The following is a description of a gene set: from publication Chaussabel D, Semnani RT, McDowell MA, Sacks D, Sher A, Nutman TB (PMID 12663451) species: Homo sapiens Monocyte-derived dendritic cells (DC) and macrophages (MΦ) generated in vitro from the same individual blood donors were exposed to five different pathogens, and gene expression profiles were assessed by microarray analysis. Responses to Mycobacterium tuberculosis and to phylogenetically distinct protozoan (Leishmania major, L. donovani, Toxoplasma gondii) and helminth (Brugia malayi) parasites were examined, each of which produces chronic infections in humans yet vary considerably in the nature of the immune responses they trigger. Genes up-regulated in comparison of macrophages exposed to L. donovani versus macrophages exposed to M. tuberculosis. Human Gene Set: GSE360_L_DONOVANI_VS_M_TUBERCULOSIS_MAC_UP, and this is the list of marker genes: GATC, HSPA1A, TRIP13, LRIT1, SORBS3, USP24, TIAM1, TUBB7P, NPC1, ACP5, CYB561D2, PECAM1, CLN3, AARS1, GRIK2, MGA, BRD2, TMEM184B, ZNF148, MOAP1, PPP2R5A, SVIL, TDRD3, EXPH5, CHST15, HYOU1, TAX1BP1, STK10, CENPS, CHERP, GFUS, COL4A5, DAB2, TFRC, MAPKAPK5, HAL, TBX19, CCR7, CUL5, TLN2 (talin 2), LY86, CALML3, GPC3, C6orf120, ALDH1B1, JADE2, RPL10, LIPA, PRIM1, RAMP1, LPAR2, DNAH7, BNIP3L, ZNF263, SERINC5, IL1R1, MERTK, SIAH1, IRF4, KDM4C, NAP1L1, C1orf216, HOMER3, PRCP, LPL, SMARCA1 (SWI/SNF related, matrix associated, actin dependent regulator of chromatin, subfamily a, member 1), SEC61B, CNPPD1, NTNG1, LDLRAD4, ABR, PAN2, ITGAX, TOMM34, PDIA4, NFYB (NCBI Gene Id 4801), NR4A3, ADGRL1, HTR2B, DPM2, IRF5, MICAL3, TRAM1, PC, CBX7, CRABP2, FGR, MAP3K14, TPD52L2, CUL2, TUBGCP3, ASNS (asparagine synthetase (glutamine-hydrolyzing)), SIX3, TBC1D9B, GARS1, MPHOSPH10, TLR5, MYOZ2, ADO, PRPF40A, RPS3A, SERPINE2, CADM1, HHLA1, AHNAK, GDI2, NUPR1, OSBPL8 (oxysterol binding protein like 8), ORC4, DDB2, LBX1 (ladybird homeobox 1), RHEB, DDIT3, FOXN3, GPNMB, PIM1, FUT6, LTA4H, USP12, ODF1, RPL12, LAMP3, SEMA5A (NCBI Gene Id 9037), CD59, PTGER3, KCNA3, TBL2, LAMTOR5, TARS1, ATP1B2, ATF4, HSPB6, COL19A1, TSC22D2, NDST1, TSPYL2, NPEPPS, CXCR4, NRF1, MISP, JUP, SUN2, SLC6A6, PRDX2, HSPA5, MRC1, SGSM2, VPS52, HEXA, MAPK8, DHX38, SYN3, STIM1, LMTK2, MYBPC2, TXNRD1, IL1RN, ITGB1BP1, MAK16, MANF, RNASE1, GRAMD4, NAT8, VGLL4, CTNNB1, IL3RA, SLIT1, IFNGR1, PABPC1, NUTF2, HMOX1, TNNC2, URB2, MKNK2, SLC6A8, CDV3, NCAPD3, TNFSF14, TAB1, CCL2, BLNK, NPM1, MGP, ADGRG6, RPL7, RPN1, TRAF4, DDX51, MUC2, KLHL21, TRIB1, PPBPP2, GAB1, S100A11, TRAF5, CCL22, ISG20L2, PFKFB1, DOC2B, PHF1 (NCBI Gene Id 5252)